The following is a description of a gene set: Human Gene Set: HP_ABNORMALITY_OF_THE_PHALANGES_OF_THE_3RD_TOE Abnormality of the phalanges of the 3rd toe studied in species Homo sapiens, and this is the list of marker genes: EOGT, LMNA, TBX5, NOG, MAP3K20